Given this list of marker genes Xkr8, Fst, Dcaf10, Shroom4, Hnf4g, Elavl4, Pcp4, Fancf, Jcad, Tcf12, Adam24, Lmo2, Rftn2, Tgfbr2, Camk2b, Exosc1, Ppp3cb, Prc1, Snu13, Fam228b, Nnat, Col3a1, Asic1, Rab39, Adgrg6, Ino80, Gnb5, Sh3gl1, St13, Neurod1, Fam184b, Pum1, Nkiras1, Ranbp17, Satb2, Ep400, Oxsr1, Retn, Afg3l2, Gnal, Kmt2a, Ppcdc, Mink1, Robo1, Aff4, Snai2, Iws1, Atg14, Fbn1, Acnat1 (NCBI Gene Id 230161), Ankrd40, Sbds, Mgat4c, Dpp10, Pcdh18, here is a description of the gene set: from publication Chen Y, Wang X (PMID 31504780) Genes predicted to be targets of miRBase v22 microRNA mmu_miR_7232_3p in miRDB v6.0 with MirTarget v4 prediction scores > 80 (high confidence targets). Mouse Gene Set: MIR_7232_3P studied in species Mus musculus